The following is a description of a gene set: studied in species Homo sapiens Genes predicted to be targets of miRBase v22 microRNA hsa-miR-299-3p in miRDB v6.0 with MirTarget v4 prediction scores > 80 (high confidence targets). from publication Chen Y, Wang X (PMID 31504780) Human Gene Set: MIR299_3P, and this is the list of marker genes: UHRF2, EIF2S3, SLC19A1, MAPK8IP3, ZNRF2, DDIT3, USP48, PAXBP1, C1orf141, PDE3A, ADD1, BTBD19, PRSS22, KRT10-AS1, LUC7L3 (LUC7 like 3 pre-mRNA splicing factor), RAB5A, OR2H1, STN1, SLC17A1, ENSG00000255537, HAO2, EPG5, TMED2, CUX1, UBE2H, YIPF3, ZNF207, ARL6IP5, RAB6A, USP54, FXN, GARIN6, TNFSF12, TCF4, OPN3, PAIP2B, PALB2 (partner and localizer of BRCA2), ABCE1, ABCB9, DKK2, FSTL4, MYNN, HSF2BP, SP4, PECAM1, PPHLN1, RAG2, ACACA, TRDMT1, ZNF800, ACAN, LINC02897, FRMD6, ZC4H2, FANCD2OS, PLTP, DCUN1D1